Given this list of marker genes Zfp979, Hnrnph3, Tekt3, Crebzf, Sh3gl1, Btn1a1, Slc5a6, Cstf3, Vipas39, Mybpc1, Wdr18, Shprh, Naip5, Ulk1, Vwde, Atp8b2 (ATPase, class I, type 8B, member 2), Naip6, Cfhr1, Cep55, Ggnbp2, Ndufs4, Zc3hav1l, Il17f, Tgtp1, Phf1, Tgtp2, Tubb4a, Cfhr2, Cfh, Ttc9 (tetratricopeptide repeat domain 9), Klra5, Npy1r, Kdm5d (lysine demethylase 5D), Lurap1l, Tspan2, Slc4a10, Cbx5, Kdm2a, Plagl1, H2bc6, Rtkn2, here is a description of the gene set: species: Mus musculus Genes predicted to be targets of miRBase v22 microRNA mmu_miR_7021_5p in miRDB v6.0 with MirTarget v4 prediction scores > 80 (high confidence targets). from publication Chen Y, Wang X (PMID 31504780) Mouse Gene Set: MIR_7021_5P